Given this list of marker genes Gngt2, Cacna2d3, Rac2, Ikbkb, Csf2rb2, Gnb3, Ighm, Gnaz, Kcne4, Sntb1, Neo1, Gjd2, Tnk2, Igf1, Ryr1, Grin3b, Ramp2, Efcab7, Casp8, Itgb2 (NCBI Gene Id 16414), H2-M10.1, Cdh7, Cdh24, Csf2, Gngt1, Sgca, Skap1, Emilin1, Kcns2, Dpp10, Itgb4, Lrrc26, Abhd12, H2-Ob, C2cd6, Catspere2, H2-Eb2, Itga3, Nox4, Gjb3, Gna13, Cav1, Kcng3, Kcns3, Kcnc4 (potassium voltage gated channel, Shaw-related subfamily, member 4), Snta1, Chrna3, Jup, Ncf1, Sntb2, Crb2, Erbb3, Gje1, Cntfr, Cdh12, Duox1, Acvr1, Olfm3, Cacnb1, Dlg1, Slc6a3, Cdh2, Atp1a4, Kcnf1, Porcn, Cntnap2, Grb2, Itga9, Chrng, Itgb8, Shc1, Gjc3, Gpr156, Ahnak, C6, C7, Il12rb1, Il23r, Utrn, Chrna1, Itga2b, Cacna1d, Slco6c1, Lrg1, Gnb4, Chrna9, Cav3, Lrrtm4, Kcnq4 (NCBI Gene Id 60613), Cdh11, Insr, Gja6, Scn1a, Trac, Atp4a, Cacnb2, Chrna4, Kcnq1, Kcnv1, Csf2ra, Chrnb2, Alcam, Lin7c, Chrnb3, Erbb2, Kcnab3, Sgip1, Dag1, Ctnna2, Catsperd, Ifnlr1, Kcnq3, Kcnc2, Cnih2, Cacna2d2 (calcium channel, voltage-dependent, alpha 2/delta subunit 2, NCBI Gene Id 56808), Calcrl, Ceacam1, Kcnj11, Cacng7, Kcne3, Rnf31, Gnaq, Kcna6, Chrne, Trbc2, Gp1ba, H2-DMb2, Osmr, Lilra6, Atp6v0d2, Coro1c, Gja3 (gap junction protein, alpha 3), H2-M5, C8a, Scn2b, Lrrc38, Scn4a, Kcne1, Gja10, Lyn, Gng5, Cacng8, Catsper2, Tmem262, Hmgb1, H2-Q10, Hcn4, Ctnna1, Kcna1, Gja5, Ptpn6, Ticam2, S100a10, Cacna1b, Tfrc, Cpt1c, Birc2, Aph1b, Gp1bb, Abcc8, Cacna2d1, Il18rap, Cdh19, Dpp6, Grm1, Ifnl3, Kcna5, Grik1, Bmp2, Pmp22, Kcnk2 (NCBI Gene Id 98453), Duox2, Acvr1b, H2-T23, H2-Ab1, Jak2, Cacna1s, Drd1, Tmed10-ps, Gja8, Cacna1a, Cacna1i, Slc7a5, Gfra1, H2-M10.6, Cd79b, Dchs1, Kcna10, Kcnma1, Hcn2, Iqce (IQ motif containing E), Kcna3, Hcn1, Htr3a, Grik5, Abhd6, Htra2, Shisa9, Gjc2, H2-M3, Ms4a2, Gng3, Itgae, Atp1b4, Irs1, Ncf4, Acvrl1, H2-M1, Kcnip2, Lrrc55, Grin3a, Itga4, Dtna, Dlg3, Tyk2, Psen1, Gabbr2, Gnat2, Il6, Grik3, Ptk2b, B2m, Stac3, Cacna1g, Itgad, Ramp3, Gng4, Grin2c, Hspa2, H2-M10.2, Nherf1, H2-K1, Gria3, Flot1, Cdh23, Itgb5, Stx1a, Krt8, Tmem249, H2-DMb1, Catsperz, Cacng5, Chrnb1, Apc, Acvr2b, Gnas, Scn3a, Kcnh1 (potassium voltage-gated channel, subfamily H (eag-related), member 1), Calm1, Kcnd1, Nox1, Iglc1, Csf2rb, H2-Aa, Kcnc3, H2-Ea, Kcnab1, Gp5, Cacng1, Flna, Amigo1, Cd247, Psenen, Wnt3a, Gnai2, Abcg8, Kcnj3, Gng2 (guanine nucleotide binding protein (G protein), gamma 2), Atp1a1, Hjv, H2-T22, Scn4b, Ap2s1, Cdh26, Casp3, Kcna2, Cacna1h, Psen2, Calcr, Gna14, Khdrbs1, Chrna6, Traf5, Itga10, Crb1, H2-M10.5 (NCBI Gene Id 333729), Catsper3, Itgav (NCBI Gene Id 76358), Noxo1, Gna12, Zap70, Ap2b1, Cacna1c, Itgam, Calm3, Kcne5, Apbb1ip, Cdh17, Cdhr18 (NCBI Gene Id 238939), Gabbr1, Gria2 (NCBI Gene Id 14800), Cltb, Stxbp5, Eps15l1, Cdh10, Kcnd2, Cacng4, Cdh20, Tlr6, Prkca, Chrna5, Cacng6, Cav2, Slc18a3, Kcnk1, Wnt9b, Pde4d, Sspn, Patj, Adam8, H2-T10, Kcng2, Atp4b, Calm2, Scn10a, Gjb4, Itga2, Scn9a, Snap25, Cybb (NCBI Gene Id 97621), Kcnmb4, Evc, Sntg2, Gng10 (NCBI Gene Id 14700), Efcab9, Itga6, Ighe, Gnb5, Nox3, Cflar, Kcnj9, C9, Kcnh2, Cacna1f, Diablo, Catspere1, H2-M10.4, H2-M9, Fadd, Sumo1, Kcns1, Gna15, Snap91, Btbd8, Gja1, Fxyd1, Fcgr4, Tfr2, Chrna2, H2-Q4, Ripk1 (NCBI Gene Id 328217), Gnb2, Cdh9, Scn1b, Grid2, H2-D1 (histocompatibility 2, D region locus 1), Gng14, Tbc1d5, Vamp2, Itgb1, H2-M11, H2-Q7, Aph1a, Ncf2, Shisa7, Kcnq2, Cbl, Itgb6, Scn2a, Igkc, H2-DMa, Itga1, Ap2m1, Gria1, Apc2, Sntg1 (NCBI Gene Id 71096), Olfm2, Ighd, Aph1c, Kcnh5, Lin7b, Gjd3, Pira13, Synj1, Kcnip4, Grin1, Ap2a2, Kcnj2, Ifnl2, Catsper1, Hcn3, Anxa2, Kcne2, Ncstn, Sgcg, Scn3b, Cttn, Slc6a6, Atp1a3, Ap2a1, Kcnj8, Ceacam2, Gng11, Cltc, Mpp7, Cdh13, Catsperg1, Fxyd2, Gjc1, Fas, Slc3a2, C8g, Tlr2, Hfe, Atp1a2, Slc5a3, Kcnip1, Inha, Gnat3, Kcnip3, Atp6v0d1, Gjb5, Glra3, Cdh1, Kcng1, Fcer1g, Kcnb2, Trf, Lime1, Igf1r, Kcnd3, Cdh18, H2-T3, Traf6, Dlg2, Kcng4, Chrna7, Abcg5, Itga5, Itgbl1, Itgb7, Kcnb1, Dlg4, Traf2, Kcnj5, Olfm1, Cdh8, Cd3e, Gnat1 (NCBI Gene Id 14685), Scn11a, Gng5c, Sdcbp, Crb3, Dmd, Grin2a, H2-Q6, Hc (NCBI Gene Id 15139), H2-Oa, Cacnb4, Gng13, Gnai3, H2-Q2, Syk, Traf3, H2-Q1, Pira12, Cdh5, Pgm5, Tgfbr1, Htr3b, Tmed10, Atp1b3, Vwc2l, Evc2, Cdh15, Cd74, Akap9, Nrn1, Vinac1, Trav18, Cdh4, Cnih3, Itga7, Flot2, Gjb1, Tgfbr2 (NCBI Gene Id 76304), Tgfbr3, Itgal, Dab2, Catsper4, Pira2, Cd6, Gja4, Sgce, Gnai1, Kcna7, Gng7, Trat1, Gna11, Grin2b, Fxyd4, Noxa1, Cacna1e, Gnb1, Shisa8, Il6ra, Insrr, Eps8, Kcnmb1, Cachd1, Cd40, Cacng3, Vcam1, Drd2, Kcnq5, Sgcb, Scn5a, Fzd8, H2-M2, Plp1, Il18r1, Kcnab2, Kcnc1, Gng8, Gjb6, Ctnnd1, Gnao1, Kcnj6, Tlr1, Mr1, Gjb2, Fkbp1a, Acvr2a, Catsperg2, Cdh3, Kcnmb3, Kcna4, Cdh6, Itga8, Sgcz, Ret, Cyba, Ston1, Ston2, Trbc1 (NCBI Gene Id 100125262), Lrrc52, Grik2, Gng12, Tspan32, Eps15, Lin7a (lin-7 homolog A, crumbs cell polarity complex component), Atp1b2, Cacng2, Ramp1, Vwc2, Grid1, Lrp6, Cacna2d4, Abcc9, Cd3g (CD3 antigen, gamma polypeptide), Grik4, Grin2d, Itgb3 (NCBI Gene Id 268495), Gria4, Cd3d, Ctnnb1, Chrnb4, Acvr1c, Catsperb, C8b, Clta, Cd79a, Gjd4, Krt19, H2-Eb1, H2-M10.3, Picalm, Chuk, Sacm1l, Itgax, Sgcd, Scn8a, Glrb, Trbv19, Kcnmb2 (NCBI Gene Id 73119, potassium large conductance calcium-activated channel, subfamily M, beta member 2), Cacnb3, Il6st, Itga11, Shisa6, Kcnv2, Cdh22, Atp1b1, Gp9 (NCBI Gene Id 54368), Mpdz, Chrnd, Sorbs1 (NCBI Gene Id 75688), Itgb2l, Gnal, here is a description of the gene set: species: Mus musculus Mouse Gene Set: GOCC_PLASMA_MEMBRANE_PROTEIN_COMPLEX Any protein complex that is part of the plasma membrane.